The following is a description of a gene set: studied in species Mus musculus part of: Interleukin-17 signaling; MyD88 cascade initiated on plasma membrane; MyD88:MAL(TIRAP) cascade initiated on plasma membrane; TRAF6 mediated induction of NFkB and MAP kinases upon TLR7/8 or 9 activation; TRIF (TICAM1)-mediated TLR4 signaling ; Toll Like Receptor 3 (TLR3) Cascade Reactome Pathway: MAP kinase activation This event has been computationally inferred from an event that has been demonstrated in another species.<p>The inference is based on the homology mapping from PANTHER. Briefly, reactions for which all involved PhysicalEntities (in input, output and catalyst) have a mapped orthologue/paralogue (for complexes at least 75% of components must have a mapping) are inferred to the other species. electronically inferred by orthology from the curated human pathway, and this is the list of marker genes: Mapk8, Map2k7, Mapk14 (NCBI Gene Id 26416), Ikbkb, Tab3, Mapk9, Ppp2r5d, Mapk7, Map3k8, Ubb, Tab1, Ube2n, Dusp7, Cul1, Jun, Dusp6, Ube2v1, Tab2, Ppp2r1b, Mapk11, Nfkb1, Vrk3, Map2k6, Mapk3, Irak1, Rps27a, Map2k4, Fos, Rps6ka5, Map2k3